Given this list of marker genes USP32, SEC61G, DENND6B, ZSWIM6, SGK1, CLINT1, CDR2, MTMR9LP, LYSMD3, SRPRA, TECR, CNPY2, ISG20, EDEM3, TARS3, UAP1, PAPSS1, GMPPB, APOA1, PI16, SPCS1, PTPRS, CYBA, HHIP, FEZ1, CDK2AP2 (cyclin dependent kinase 2 associated protein 2), GPAA1, ABHD8, ITFG2, TCEAL9, CYB561, SLC26A1, VRTN, CFAP54, ABHD12, ENKD1, THAP3, COL13A1, TSC1 (NCBI Gene Id 7248), ST6GAL1, RANBP9, C2orf88 (NCBI Gene Id 84281), GCHFR, ZKSCAN2, OAF, CYP11B2, SPCS3, CRYGC, ICAM2, SMPDL3B, ATP2A2, NDUFB4, GPR35, PRDX4, ALG10, IGLV4-3, IGLV4-60, GSTP1, SEC63, RGS2, CDH19, SFTPD, C15orf61, SLC16A14, SIL1, FGD5-AS1, HR, SERPINB10, FAM8A1, CCDC88A, GALNT2, SLC45A4, RPL23AP53, TPD52, CST3, IGKV3-20, ANO8, GPX3 (NCBI Gene Id 2878), SSR1, ABCG8, ALG14, PRKRA, LRIG1, MYDGF, TMEM214, CCDC14, TMED9, MIR22HG, YPEL1, UBXN10, COPB2, MYEOV, SWT1, CHPF2, FAM114A1, STARD5, PRKAR1B, SYNE2, CBX4, COPZ1 (COPI coat complex subunit zeta 1), MAGEF1, IFI27L1, SEC24A, GLG1 (NCBI Gene Id 2734), SLC39A8, RAPGEF2, STX5, MCEE, CDRT4, EIF3J, RAB5A, ZMYND10, TRAM2-AS1, P4HA2, CCNC, H2AC8, IGHM, FUT10, DHRS9, PTPN23, TNNT2, CXXC4, COPZ2, ALG2, GABARAPL1, B3GNT2 (UDP-GlcNAc:betaGal beta-1,3-N-acetylglucosaminyltransferase 2), SEC23B (NCBI Gene Id 980), TMEM208, SLC43A1, IDE, SCN4A, IL17RB, SLC1A5, TPP2, NEDD9, APBA2, GORASP2 (NCBI Gene Id 26003), FBH1, SLC35B1, AP3D1, VAT1, HM13, EIF2AK3, H2BC6, EVI5L, PPCDC, CDX1, KLHDC2 (NCBI Gene Id 23588), MAN1A1, TSPAN4, STOML1, AVPI1 (NCBI Gene Id 60370), PDIA5, SPACA9, APOM, RNGTT, TSPAN1, RLN3, PLK5, TLX1, TP53I3, SETDB2, DERL1, LINC00347, OSTC, ABCC4, TMEM39A, PSAT1, PHGDH, RPS27L, CLDN9, CDSN, TXNDC15, RASSF8-AS1, PCTP, UGGT2, GP1BB, UBA5, BTG2, PSMC2, TMEM88, PREB, TMEM184B, CCPG1, PTP4A2, CHST12, DYSF, SHB, WDR45, EIF4E3 (eukaryotic translation initiation factor 4E family member 3), H2BC5, here is a description of the gene set: studied in species Homo sapiens Genes up-regulated in plasma cells versus memory B cells. Sorted B cells using flow cytometry. CD19 selected B cells were sorted using flow cytometry. Human Gene Set: GSE12366_PLASMA_CELL_VS_MEMORY_BCELL_UP from publication Longo NS, Lugar PL, Yavuz S, Zhang W, Krijger PH, Russ DE, Jima DD, Dave SS, Grammer AC, Lipsky PE (PMID 19023113)